Given this list of marker genes Cav1, Dusp22, Ibtk, Lilrb4b, Ahsg, Lilrb4a, Hyal2, Ptprc, Cep43, Rack1, Socs3, here is a description of the gene set: Mouse Gene Set: GOMF_PROTEIN_TYROSINE_KINASE_INHIBITOR_ACTIVITY studied in species Mus musculus Stops, prevents or reduces the activity of a protein tyrosine kinase.